The following is a description of a gene set: from publication Gao S, Yan L, Wang R, Li J, Yong J, Zhou X, Wei Y, Wu X, Wang X, Fan X, Yan J, Zhi X, Gao Y, Guo H, Jin X, Wang W, Mao Y, Wang F, Wen L, Fu W, Ge H, Qiao J, Tang F (PMID 29802404) species: Homo sapiens Human Gene Set: GAO_LARGE_INTESTINE_24W_C1_DCLK1POS_PROGENITOR, and this is the list of marker genes: COLEC12, ISLR, COL5A2, COL1A1, COL5A1, TPST1, SERPINF1, GFRA2, DCN, LUM, LOX, LAMA2, CLDN11, COL14A1, MYC (MYC proto-oncogene, bHLH transcription factor), RCN3, PHC1, IFI6, QSER1, GPC6, OLFML1, PCOLCE, SPON2, IFIT2, LRRC17, FBLN1, MRC2, MAPK10, TNFAIP6, CSF1, PRICKLE1, SCUBE2, PLAGL1 (PLAG1 like zinc finger 1), HTRA1, ZNF469, CYBRD1, BOC, SPON1, COL8A1, HYCC1, PDGFRL, BASP1, PDPN, SERPING1, GSTM5, SFRP2, SVEP1, PIEZO2, COL1A2, CCDC80, GBP1P1, ADAMTS4, C1QTNF3, HAPLN3, MATN2, PAMR1, THBS2, DPT, TTYH2, SRPX, IFIT3, C3 (NCBI Gene Id 12266), MMP2, SCN7A, CPZ, GBP1, NNMT, SPARC, C7 (NCBI Gene Id 636878), COL6A6, OGN, VCAM1, TMEM59L, ICAM1, SPTLC3, MX1, VASN, CPXM1, AZIN2, C1S, COL16A1, SFRP1, ASPN, CERCAM, LPAR1, NGFR, RERG, ADAMTS2, MGP, CTHRC1 (collagen triple helix repeat containing 1), FZD1, COL3A1, VCAN (versican), FNDC1 (fibronectin type III domain containing 1), CCL2, CLEC11A, C1QTNF6, ADAMTS1, C1R